The following is a description of a gene set: A structural anomaly of the nasopharynx. Human Gene Set: HP_ABNORMAL_NASOPHARYNX_MORPHOLOGY studied in species Homo sapiens Abnormal nasopharynx morphology, and this is the list of marker genes: IGKC, TMCO1, DNAAF4, SOX11, POLD1, KATNIP, NME5, DPF2, PRKCD, GNPTAB, SMARCC2, CTLA4, CREBBP, CIITA, ZBTB7A, NAGLU, PLG, PDE11A, TBK1, COL5A2, PRKAR1A, OFD1, KRT5, RNF168, ARID2, DNAI2 (dynein axonemal intermediate chain 2), PIK3R1, POLE, ACBD6, SPI1, MYSM1, NFKB1, IL17RA, CFAP74, ADNP, TNFRSF1A (NCBI Gene Id 8077), SASH3, CFI, NFIX, SCNN1A, P4HA2, MDM4, SLC4A10, HGSNAT, DEAF1, LRBA, ADA, SMARCD1, MAGT1 (magnesium transporter 1), STK11, C4B, CARMIL2, IGHG2, BRWD1, XIAP, SGSH, COL5A1, PHIP, KDM5C, CD4, RAG2 (NCBI Gene Id 5897), ARHGEF1, UNC119, IGHM, TP63, GALNS, SCNN1B, PSMB8, SPAG1, ODAD1 (NCBI Gene Id 93233), STK4, BTK, STXBP2, STX3, MST1R, ALMS1, IVNS1ABP, COG4, IFIH1, CD19, SETBP1, NEK10, UNG, IL7R, TNFRSF13C, DCLRE1C, ODAD2 (NCBI Gene Id 84104), G6PC3, POLD3, SALL4, IL6R, FCGR3A, GUSB, SLC37A4, MGAT2, STAT1, TP53, NCF4, DNAAF5, DYM, IL6ST, HCK, FOXN1, CXCR4 (NCBI Gene Id 93405), ARID1B, GLB1, NFKB2 (NCBI Gene Id 4791), DNAAF2, ARSB, USB1, UQCRH, ZNF341, SCNN1G, ACP5, GJA1, RSPRY1, SMARCA4, RAC2, GNS, EP300, IRF2BP2, ZBTB24, STK36, JAK3, SLC29A3, PNP (NCBI Gene Id 4860), IL21R, RAG1, IKBKB, ADA2, RSPH1, SMARCB1 (NCBI Gene Id 6598), GLI3, USP9X, ZMYND10, TNFRSF9, HYDIN, ARID1A, SHH, MGP, CORO1A, FOXP1, PIK3CD, NFKBIA, ALG12, FOXJ1, TNFRSF13B, AICDA, MBTPS2, ICOSLG, MDFIC, DNAAF1, HPS6, PRPS1, HYOU1, STAT3, DNAJB13, SMARCE1, BLM, CFAP298, DNAH5, SOX9, PTPN22, RNH1, DNAAF6, ZAP70, WAS, DOCK8, CCDC65, RELB, IKBKG, GAS2L2, SEC61A1, MID1, PLVAP, TBC1D24, PTEN, SH2D1A (NCBI Gene Id 4068), SH3KBP1, SOX4, LEPR, DNAAF11, ICOS, RAI1, RFXANK, HLA-DRB1, RSPH4A, MCIDAS, HLA-B, IQSEC2, LEP, IDS, NME8, CR2, ASAH1, LCK, FLII, TBX1